The following is a description of a gene set: studied in species Homo sapiens Human Gene Set: GOBP_REGULATION_OF_CARDIAC_MUSCLE_CONTRACTION_BY_REGULATION_OF_THE_RELEASE_OF_SEQUESTERED_CALCIUM_ION Any process that modulates the frequency, rate or extent of cardiac muscle contraction via the regulation of the release of sequestered calcium ion by sarcoplasmic reticulum into cytosol. The sarcoplasmic reticulum is the endoplasmic reticulum of striated muscle, specialised for the sequestration of calcium ions that are released upon receipt of a signal relayed by the T tubules from the neuromuscular junction., and this is the list of marker genes: FKBP1B (NCBI Gene Id 2281), SLC8A1, RYR2, FKBP1A, TMEM38A, TMEM38B, ASPH, GSTM2, HRC, ANK2, CALM1, PRKACA, CALM3, CAMK2D, CLIC2 (chloride intracellular channel 2), PLN, ATP1A2, CASQ2, DMD, TRDN, MIR133A1, CALM2, MIR1-1, GSTO1, CACNA1C